Given this list of marker genes TADA3, KAT2A, TAF4, SUPT7L, TAF6, SGF29, SAP130, TAF6L, TAF5, TAF5L, TAF10, ADA, TAF12, ATXN7, TRRAP, TAF9, SUPT3H, TAF2 (NCBI Gene Id 6873), here is a description of the gene set: from publication Nagy Z, Tora L (PMID 17694077) Human Gene Set: NAGY_TFTC_COMPONENTS_HUMAN Composition of the 2 MDa human TFTC complex containing KAT2A. Transcription in eukaryotes is a tightly regulated, multistep process. Gene-specific transcriptional activators, several different co-activators and general transcription factors are necessary to access specific loci to allow precise initiation of RNA polymerase II transcription. As the dense chromatin folding of the genome does not allow the access of these sites by the huge multiprotein transcription machinery, remodelling is required to loosen up the chromatin structure for successful transcription initiation. In the present review, we summarize the recent evolution of our understanding of the function of two histone acetyl transferases (ATs) from metazoan organisms: GCN5 and PCAF. Their overall structure and the multiprotein complexes in which they are carrying out their activities are discussed. Metazoan GCN5 and PCAF are subunits of at least two types of multiprotein complexes, one having a molecular weight of 2 MDa (SPT3-TAF9-GCN5 acetyl transferase/TATA binding protein (TBP)-free-TAF complex/PCAF complexes) and a second type with about a size of 700 kDa (ATAC complex). These complexes possess global histone acetylation activity and locus-specific co-activator functions together with AT activity on non-histone substrates. Thus, their biological functions cover a wide range of tasks and render them indispensable for the normal function of cells. That deregulation of the global and/or specific AT activities of these complexes leads to the cancerous transformation of the cells highlights their importance in cellular processes. The possible effects of GCN5 and PCAF in tumorigenesis are also discussed. species: Homo sapiens